The following is a description of a gene set: studied in species Mus musculus Mouse Gene Set: chr12F1, and this is the list of marker genes: Ighv7-2, 4930511J24Rik, Dync1h1, Dio3os, 9230104M06Rik, Gm17031, Dio3, Eml1, Tedc1, Ighv7-1, Bcl11b, Wars1, Gm40576, Crip1, Ighv3-7, Gm23787, Ighd2-3, Gm36635, Rd3l, Ighv3-2, Ighd5-7, Mir1188, Mir541, Mir3072, Mir668, Ighj1, Gm9517, Ighd5-3, Mir342, Inf2, Mir431, Ighv2-9, Ighv5-5, Ighe, Mir410, Mir434, Gm25856, Ighv11-1, Ighd5-2, Mir134, Mir376b, Xrcc3, Mir6940, Ighv6-4, Ighv5-3, Mir154, Cyp46a1, Ighv9-3, Igha, AF357428, Mir496a, Coa8, Gm46379, Ighv5-11, Ccnk, Ighd6-2, Traf3 (NCBI Gene Id 22031), Ighv3-6, Ighv5-15, Gm7003, Gm22981, A230087F16Rik, Gm35558, Mir665, Ighv2-7, 1700121N20Rik, Meg3, Ighv9-4, Ighd1-1, Gm9136, Mir136, 4933406K04Rik, Mir329, Gm23347, Ppp1r13b, Mir453, Mir1193, Ighv12-1, Ckb, Ankrd9, Ighd2-5, Mir673, Ighv13-1, 4930595D18Rik, Nudt14, Ccdc85c, 5033406O09Rik, Mta1, Mir341, Gm25224, Gm6988, Gm22079, Ighd5-8, Mir6941, Ighv2-9-1, Bag5, Slc25a29, Ighv2-5, Mir666, Zbtb42, Mir409, Ighv3-5 (NCBI Gene Id 633457), Cinp, Mir1197, Gm3191, Ighv5-8, Rpl26-ps3, Gm3565, Mir380, 5033424D13Rik (NCBI Gene Id 75975), Mif-ps7, Gm9599, Gm266, Gm9661, Snora28, Gm23736, Ighv3-3, Ighv5-19, Mir3071, Gm9006, Clba1, Rian, Gm26583, Kif26a (NCBI Gene Id 668303), Mir539, Ppp2r5c, B020018J22Rik, Mir299a, 1700013N06Rik, 2810029C07Rik, Mir376c, Ighv2-2, Gm25854, Tnfaip2, Eif5, Hsp90aa1, Tex22, Mir381, Cep170b, Ighv3-1, Trmt61a, 4930478K11Rik, Ighd2-7, Mark3, Dlk1, Akt1, Mir487b, Mir654, Gm10425, Ighv5-12, Ighv2-6, Gm33467 (predicted gene, 33467), Mir6939, Mirg, Ighv9-2, Mir3544, A530016L24Rik, Mpc1-ps, Gm18551, Mir300, Klc1, Exoc3l4, Mir1906-1, Ighd5-1, Mir337, Mir495, B930059L03Rik, Mir882, Amn, Rtl1, Ighd6-1, Mir758, Mir433, Gm24564, Wdr25, Ighv5-12-4 (NCBI Gene Id 630837), Ighv5-10, Gm9063, Ighv2-1, Mir544, Yy1, Gpr132, Rcor1, Mir376a, Ighd2-8, Gm19605, Ighm, Ighv6-3, Gm30238, Ighv5-17, Gm22205, Gm25357, Ighg1, Ighd3-2, Gm16596, Ighd, Mir493, Mir369, Tdrd9, Gm33682, Zfp839, Mir485, Gm34081, Mir3073b, Ighv2-6-8, Jag2, Mok, 4921507G05Rik, Gm34719, Ighv5-2, Ighd5-4, Ighv5-16, Mir667, Ighv14-1, Ighv5-7, Hhipl1, Ighg3, Ighv14-3, Btbd6, Ighv14-4, Pld4, 3110018I06Rik, Mir382, Gm17052, Gm26922, Mir203 (microRNA 203), Ighj4, Mir543, Ighv5-6, Ighj2, Ighg2c, Mir540, Gm34220, Mir411, DQ267100, Ighv4-1, Gm16084, Gm5189, Mir370, Mir679, A730018C14Rik, Ighv2-3, Gm36757, Cdc42bpb, AF357341, 4930425K24Rik, Ighv14-2, Atp5mj, Mir432, Ighv4-2, Ighg2b, Aspg, Mir3073a, Crip2, DQ267101, Gm20368, Mir127, Ighv5-18, Mir770, Ighv5-13, Wdr20, Mir1247, Tecpr2 (NCBI Gene Id 217862), Adam6a, Gm34785, Pacs2, Ighv9-1, Gm9134, 1700001K19Rik, Mir412, Ighv2-4, 1700127F24Rik, Mir379, Ighv3-4, Ighv5-4, Ighd5-5, Ighv6-1, Adss1, Ighv8-1, Gm3234, Ighd4-1, Tmem179, Ighv6-2, Gm15636, Evl, Gm23508, Slc25a47, Begain, Brf1 (NCBI Gene Id 72308), Lbhd2, Mir323, Ighd5-6, E330035G20Rik, Ighv5-9-1, Ighv5-21, Ighv7-4, Ighv13-2, Gm32635, Ighj3, Setd3, Ighd2-4, Ighv12-3, Ighv5-1, Gm5190, Ighv2-8, Mir345, Rps19-ps6, Gm16087, Gm25622 (predicted gene, 25622), Gm19195, Siva1, Tmem121 (NCBI Gene Id 69195), Gm17053, 4930465M20Rik, Mir299b, Ighv3-8, Ighv5-9, Degs2, Gm2800, Ighv16-1, Ighv7-3, Ighv1-1, Ighv15-1, Adam6b, 6030440G07Rik, Ighv11-2, Ighv12-2, DQ267102, Ighd2-6, Cdca4, Gm18405, Zfyve21, Mir494, Gm5187, Ighd3-1, Mir377, 3110009F21Rik, Gm3379